Given this list of marker genes CDH2, KCNA4, ETFDH, TKT, FBLN5, RNU7-1, BEST1, ERCC2, GNAQ, MED13L, MT-TK, MT-ND6, SNUPN, PEX5, NAA60, RAB18, HEATR3, RPL5, KDM6A, TCTN2, MT-TS2, HCCS, RPL27, SIL1, COL4A5, SH3PXD2B, SALL4, HS2ST1, TREX1 (NCBI Gene Id 82474), FGF3, DLX5, FANCM, TMEM237, SDHC, LARGE1, NDUFB11, MAD2L2, IGF1R, NSD2, TMEM107, TBC1D20, GFER, WDR37, B9D2, LRP2, BRIP1, TCTN3, B9D1, MT-TF, WNT10B, ARPC4, FANCB, FKBP6, TMEM216, RPS24, NUP188, RPGRIP1, SEC31A, FANCA, RPS26, WDR73, VHL, B3GAT3, RPL35, MAB21L1, ADAMTSL1, METTL27, FANCI, RAB3GAP1, LIMK1, NEU1, PAX3, RBP4, HMX1, CTBP1, PEX7, RPL11, COL2A1, LDHD, FANCG, IDH1, IFIH1, RPS17, CRYBB3, CRYAA, SIX6, POMT1, CRYGB, PHGDH (phosphoglycerate dehydrogenase), ERCC8, MT-CO1, BMP4, MYOC, PITX3, NCF1, FGFR1, TELO2, PEX11B, ITPR1, VPS37D, DAG1, RNASEH2B, AKT1 (NCBI Gene Id 207), LAMB2, SDHB, KIF1B, TMEM67, DNAJC30, TRIM28, RPL31, CSPP1, GTF2H5, RNF113A, DOCK6, BFSP2, ADAMTS17, DLST, KMT2C, SDHA, ALDH18A1, BAZ1B, SBF2, MIR184, COX7B, RECQL4, EIF4H (eukaryotic translation initiation factor 4H), ADA2, RPS15A, PRR12, ETFA, ERCC6, DNA2, SLC2A10, MITF, KCTD1, CHD6, CHST3, RPS19, POMT2, FLNA, RPL8, TCTN1 (NCBI Gene Id 79600), EPS15L1, RPS27, CARS1, TP63, BUD23, PRDM5, POU6F2, NF1, ADAR, MAX, STX1A, FKRP, CRYBA1 (NCBI Gene Id 8146), XRCC2, GTF2I, COL4A1, MAFB, TMEM231, SLX4, EPG5, FZD4, SLC38A8, FANCF, CPLX1, RPL26, DLX6, FAM111A, RFC2, ATOH7 (atonal bHLH transcription factor 7), MT-TW, MAF, CRYAB, RPS29, TBL2, ETFB, TMEM127, ERCC3, ANAPC1 (NCBI Gene Id 64682), LMNA, COL18A1, PSMC3, JAG1, CC2D2A, CRYBB2, CRYGC (crystallin gamma C), RPS7, HYCC1, RAB3GAP2, EPHA2, PIGY, TARS1, CRYBA2, POMGNT1, RFWD3, FUT8, FBXW11, CRPPA, ENTPD1, IARS2, VPS4A, MT-CYB, GTF2IRD2, GFAP, GPC3, TRIP13, KMT2D, SAMHD1, RRAGC, SLC33A1, RPL18, TWIST1 (NCBI Gene Id 7967), DPAGT1, SIPA1L3, MKS1, ATAD3A, MT-CO3 (mitochondrially encoded cytochrome c oxidase III), CRYBB1, FANCE, RPL15, RAD51, VSX1, FOXE3, MED25, BCOR, FANCC, FOXC1, RNASEH2C, UBE2T, KANSL1, FGFRL1, MPLKIP, WT1, PXDN, GTF2E2, TSR2, SDHAF2, REST, PITX2, MAFA, ERCC4, ELP4, BDNF, TONSL, GCNT2, ZNF469, MT-ND5, TEK, GTF2IRD1, SLC25A11, MT-TL1, FKTN, LONP1, UBE2A, GLIS3 (NCBI Gene Id 648268), FBN1, PYCR1, ELN, RIC1, LSM11, RPS10, FBXW4, RPL35A, CANT1, NHS, RPS20, CTDP1, PNPT1, EHMT1, LETM1, RET, CAV1, MT-CO2 (mitochondrially encoded cytochrome c oxidase II), AARS1, CLIP2, TXNDC15, RNASEH2A, LSS, DIS3L2, RPGRIP1L (RPGRIP1 like), FGFR2, TENM3, MT-TC, BTRC, PIK3C2A, CHN1, ZEB2, SMC5, ERCC1, NDP, PIEZO2, HHAT, FANCL, CEP290, XYLT2, SEM1, BRCA2, MT-TQ, FH, RAD51C, SOX10, BRCA1, AGK, TRIM44, MT-ND1, STIM1, CRYGD, MIR204, HSPG2, PORCN, GATA1, ADAMTS10, TMEM270, CYP1B1, PAX6, MSMO1, PALB2, SDHD, FANCD2, LMX1B, H19, MDH2, PIK3R1, LTBP2, RERE, B3GLCT, RPL9, CENPF, NCAPG2, ABCA2, SRY, OCRL, MT-TV, RPS28, CPAMD8, here is a description of the gene set: species: Homo sapiens Abnormal development (dysgenesis) of the anterior segment of the eye globe. These structures are mainly of mesenchymal origin. Ocular anterior segment dysgenesis Human Gene Set: HP_OCULAR_ANTERIOR_SEGMENT_DYSGENESIS